Given this list of marker genes Ceacam1, Gpaa1, Vnn1, Ceacam2, Dpep1, Pigu, Mppe1, Thy1, Fcgr4, here is a description of the gene set: species: Mus musculus Mouse Gene Set: GOMF_GPI_ANCHOR_BINDING Binding to a glycosylphosphatidylinositol anchor. GPI anchors serve to attach membrane proteins to the lipid bilayer of cell membranes.